The following is a description of a gene set: Autophagy, a distinct pathway of programmed cell death, is used by the phagocyte primarily to eradicate damaged cell organelles or unused proteins. As Mtb damages the phagosomal membrane it has to block autophagy processes to ensure maximum replication before exit from the cell. species: Homo sapiens part of: Response of Mtb to phagocytosis Reactome Pathway: Suppression of autophagy, and this is the list of marker genes: sapM, RAB7A, DUSP16, eis